Given this list of marker genes Chmp4b, Tuba3a, Atg4c, Chmp2b, Tubb4b, Arl13b (NCBI Gene Id 77950), Uba52rt, Gabarapl1, Chmp3, Prkaa1, Pik3c3, Atg4b (NCBI Gene Id 98652), Dync1i1, Mtor (NCBI Gene Id 80612), Dync1li1, Lamtor5, Lamtor4, Atg4a, Csnk2b, Atg9a, Dync1li2, Tubb1, Ubc, Atg9b, Prkab1, Rheb, Tbk1, Mfn1, Sqstm1, Wdr45b, Slc38a9, Cetn1, Chmp2a (NCBI Gene Id 68953), Nbr1, Usp30, Atg12, Tomm6, Atg7, Vim, Ube2n, Rb1cc1, Atg3, Mterf3, Atg16l1, Atg16l2 (autophagy related 16 like 2), Tubb2a, Tsc1, Ube2v1, Tomm20, Dynll2, Tubb4a (tubulin, beta 4A class IVA), Mlst8, Wipi1, Tubb2b (NCBI Gene Id 73710), Tsc2, Map1lc3a, Tuba3b, Tomm70a, Rragd, Csnk2a2, Tubal3, Uvrag, Tuba8 (tubulin, alpha 8), Pik3r4, Tuba1b, Tuba1c, Tomm22, Chmp4c, Uba52, Vdac1, Dynll1, Tubb3, Prkaa2 (protein kinase, AMP-activated, alpha 2 catalytic subunit), Vdac3, Rps27a, Pgam5, Atg13, Dync1h1, Ambra1, Dync1i2, Tubb6, Ulk1, Atg5, Rptor, Ube2l3, Atg4d, Vdac2, Gabarapl2, Fundc1, Atg101, Tuba4a, Lamtor3, Mtmr14, Src, Mfn2, Cftr, Tomm40, Tuba1a, Wipi2, Map1lc3b, Csnk2a1, Park7, Prkag3, Prkab2, Tomm5, Mtmr3, Rragb, Prkn, Optn, Atg14, Chmp7, Hdac6, Becn1, Rragc, Chmp6, Wdr45, Ube2d3, Gabarap, Pink1, Ube2d2a, Atm, Rraga, Lamtor2, Lamtor1, Prkag2, Pex5, Tomm7, Prkag1, Ubb, here is a description of the gene set: Mouse Gene Set: REACTOME_MACROAUTOPHAGY Macroautophagy species: Mus musculus